The following is a description of a gene set: part of: Interleukin-2 family signaling This event has been computationally inferred from an event that has been demonstrated in another species.<p>The inference is based on the homology mapping from PANTHER. Briefly, reactions for which all involved PhysicalEntities (in input, output and catalyst) have a mapped orthologue/paralogue (for complexes at least 75% of components must have a mapping) are inferred to the other species. species: Mus musculus electronically inferred by orthology from the curated human pathway Reactome Pathway: Interleukin-9 signaling, and this is the list of marker genes: Stat5b, Il2rg, Jak3, Il9r, Il9, Stat5a